The following is a description of a gene set: species: Homo sapiens from publication Chow KT, Schulz D, McWhirter SM, Schlissel MS (PMID 24086657) Human Gene Set: GSE45837_WT_VS_GFI1_KO_PDC_UP Growth factor independence genes (Gfi1 and Gfi1b) repress recombination activating genes (Rag) transcription in developing B lymphocytes. Because all blood lineages originate from hematopoietic stem cells (HSCs) and different lineage progenitors have been shown to share transcription factor networks prior to cell fate commitment, we hypothesized that GFI family proteins may also play a role in repressing Rag transcription or a global lymphoid transcriptional program in other blood lineages. We tested the level of Rag transcription in various blood cells when Gfi1 and Gfi1b were deleted, and observed an upregulation of Rag expression in plasmacytoid dendritic cells (pDCs). Using microarray analysis, we observed that Gfi1 and Gfi1b regulate a broad spectrum of cellular processes in pDCs, but not a lymphoid specific transcriptional program. This study establishes a role for Gfi1 and Gfi1b in Rag regulation in a non-B lineage cell type Genes up-regulated in plasmacytoid dendritic cells: wildtype versus GFI1 knockout., and this is the list of marker genes: TRH, PDK3, NES, IGLV3-19, STK38L, ANAPC2, ARHGAP33, SH2D3C, ULK1, PART1, LINC00216, SPPL2B, THRAP3 (NCBI Gene Id 9967), SLC17A3, GSTA3, ATAT1, AGO2, PLPPR2, SLC66A3, RNF24, PPP2R2B, SCN3A, PAK3, ZNF654, TRPM6, BMAL1, MTMR9, NID1, AUNIP, AQP9, FOXJ2, CYBRD1, EP300, ITGA5, UTRN, EDEM3, SEC14L1P1, KRT2, MAP3K3, PRPF40A, TRABD, ZBTB16, RARA, MOCOS, MTMR11, TRIM2, LORICRIN, ATG16L1, DNAJB4, MAGEA3, HNRNPH1, SPACA1, TMEM41B, EFHC2, OR2B6, ZBTB43, CD1B (CD1b molecule), CORO2B, WASF3, INO80B, SCUBE3, ARPP21, SLC5A3, H2BC21, TSPYL2, CWH43, DAB2 (DAB adaptor protein 2), SLC30A10, DVL3, RRBP1, IGLJ3, RBFOX2, BNC2, HMGCS2, PCDHB17P, SLC17A9, IVNS1ABP, ZNF324, SYTL2, MSL2, HLA-A, BSDC1, SPAG9, RBM26, CPN2, BTN2A3P, BMS1P20, C1orf105, FAM222B, SATB1 (NCBI Gene Id 6304), LMAN1 (NCBI Gene Id 3998), CNGA3, SSX2IP, CUBN, BTN1A1, SLC35D1, SPATA6L, GUCY1A1, FEZ1, PDE8B, RHOBTB3, FLCN, RABL6, DEFB126, TMEM176B, SAGE1, FURIN (NCBI Gene Id 5123), PRKAB2, BRAF (B-Raf proto-oncogene, serine/threonine kinase), LARGE1, NELL1, POPDC3, NCAPG2, EOLA2-DT, CDH6, OR2B2, C2CD2L, PROSER1, CLOCK, CCZ1B, LUZP4, HGS, GTF2H2B, BCO1, CALU (calumenin), OBSL1, NEIL1, KCNMB1, WNT2, TPP2, TRIM48, PGAP1, FANCG, PLAC4, ARMCX3, BTBD18, ASB4, DENND2B, SASH1, RPS6KA6, ABCB1, SGSH (N-sulfoglucosamine sulfohydrolase), CD93, SAMD4A, SLC5A7, STX1A, CEP85, MYH14, ADCY6, VAMP2, RUFY2, IGKV3-20, SLC2A2, PRKCD, HOXA10, ANOS1, GUCA1A, ADAM20, NKTR, RORA, SLC11A2, ZBTB44, CHODL, HGSNAT (heparan-alpha-glucosaminide N-acetyltransferase), FAM135A, CGA, WDR70, ALOX12, HNRNPL, ITIH2, CLEC1A, KPNA6, LATS1, ERN1, CDK9, PSG11, TSPAN12, SLC30A6 (NCBI Gene Id 55676), IL17A (interleukin 17A), FHL5 (four and a half LIM domains 5), ODR4, CLTCL1, TPD52L1, CYP3A5, HOXA5, FASN (fatty acid synthase), IDUA, SUPT6H, TNFAIP2, CASP10, RAD54L2, HIP1, DDX21, CSN3, ADGRA3